Given this list of marker genes Fam3a, Them6, Ssrp1, Terf2, Dmxl2, Styx, here is a description of the gene set: Mouse Gene Set: CUI_ILC_CD27L_RESPONSE_UP from publication Cui A, Huang T, Li S, Ma A, Pérez JL, Sander C, Keskin DB, Wu CJ, Fraenkel E, Hacohen N (PMID 38057668) Cytokines mediate cell-cell communication in the immune system and represent important therapeutic targets. A myriad of studies have highlighted their central role in immune function, yet we lack a global view of the cellular responses of each immune cell type to each cytokine. To address this gap, the authors created the Immune Dictionary, a compendium of single-cell transcriptomic profiles of more than 17 immune cell types in response to each of 86 cytokines (>1,400 cytokine-cell type combinations) in mouse lymph nodes in vivo. A cytokine-centric view of the dictionary revealed that most cytokines induce highly cell-type-specific responses. For example, the inflammatory cytokine interleukin-1β induces distinct gene programmes in almost every cell type. A cell-type-centric view of the dictionary identified more than 66 cytokine-driven cellular polarization states across immune cell types, including previously uncharacterized states such as an interleukin-18-induced polyfunctional natural killer cell state. species: Mus musculus Genes positively differentially expressed in cell type: ILC (innate lymphoid cell) upon treatment with cytokine: CD27L in mouse lymph nodes in vivo.